Given this list of marker genes UPF3A, CDC45, RPA1, MKI67, POLR1HASP, IQSEC1 (NCBI Gene Id 9922), PLK1, MELK, SORT1, FEN1, CDK4, CENPA, ALOX12B, KPNA2, PTK7 (NCBI Gene Id 5754), SPATA9, TOP2A (NCBI Gene Id 7153), TSPYL4, PTPN23 (protein tyrosine phosphatase non-receptor type 23), NEK2, CCNB1, PRKX, PCNA, H2AZ1, CDC20, PCNT, CDK1, MKS1, ESRP1 (NCBI Gene Id 54845), RNFT2, TOPBP1, MYBL2, NLRC4, here is a description of the gene set: Genes in the cancer module 451. studied in species Homo sapiens Human Gene Set: MODULE_451